The following is a description of a gene set: Murine Cytomegalovirus (MCMV) infection leads to early activation of various immune cells, including B and T lymphocytes, before the actual initiation of antigen-specific adaptive immunity. This activation is partly driven by innate cytokines, including type I interferon (IFN), which are induced early after infection. The objective of this study was to address the role of type I IFN in shaping early/innate B and T cell responses to a primary acute viral infection. In order to decipher the specific impact of IFN-I on cell subsets, we performed a genome-wide expression analysis on WT splenic B and CD8 T lymphocytes isolated from C57BL/6 mixed bone marrow chimera mice. This study complements series GSE39555, which focused on early responses of NK cells and of the two subsets of conventional dendritic cells. Human Gene Set: GSE45365_NK_CELL_VS_CD8_TCELL_MCMV_INFECTION_DN species: Homo sapiens Genes down-regulated during primary acute viral infection: NK vells versus CD8 T cells., and this is the list of marker genes: H2BC9, SEC61B, AKAP13, NFKB2, CHST7, TNFRSF1B, SND1, CHKB, PLAAT3, REPIN1, ETV3, H6PD, SMG9, SQSTM1, FAAH, B3GALT4, PSME2, ALOX15B, CD80, F11R (F11 receptor), EOLA1, TMEM268, TXN, SYNGR2, ACSM1, ZEB1, VPREB1, PRIM2, TNFAIP2, PIEZO2, ICOSLG, SPRED2, RAB5B, GBP1 (NCBI Gene Id 2633), CLU, NFKBIA, RAB11A, MPPED1, FSCN1, ACOXL, PSME1 (proteasome activator subunit 1), NAT8B, TRIP10, CLUHP3, PLK2, PRAME, HSPA8, LLGL2 (NCBI Gene Id 3993), CMTR1, STAP2, GPX4, NBL1, RAB8B, EOLA2, NFKB1, PPP1R16B, GATA6, SLC30A3, PSMD4, DUSP26, ST8SIA1, BIRC3, PTPN1, CEACAM1, GRK3, H3C10, GNG5, TBX5, GADD45A, EIF1, EDN1, TANK (NCBI Gene Id 10010), SLC2A6 (NCBI Gene Id 55587), THNSL2, SH3GL2, CDKN2A-AS1, ACY1, ACOX2, CDH11, UPB1, NRP2, CSNK1G3, MCC, UFD1, HAX1, MARCKSL1, CCDC81, ZMIZ2 (NCBI Gene Id 83637), LMBR1L, RFTN1, BMAL2, MIIP, ABCA7, LRRC8E, TRADD (TNFRSF1A associated via death domain), JAK3, CD40, TRAF1, SNN, LY75, LIPG, UNC13A, TNFRSF9, STX4, N4BP2L1, CERS6, SPON2, PRLH, RASSF4, MAP4K4, LSP1, KIF2A, EFR3B, CCL19, HTRA2, NCOA3, FLT3, IL2RA, BASP1, MED13L, NOSIP, ENOX1, PTGIS, MTCP1, MRPL46, RELB, SOCS2, TNIP1, TWF2, EBI3, DUSP1, EEF1A1, MED12, STAT5A, CLASRP, TAP1, CCL22, SLC5A6, MYBPC2, PSMC4, RNF115, CD70, REL, ZFTA, FOXO1, KRT19P2, POGLUT1, P2RY10, SLC1A2, CFP, PSMB10, ENSA, TNFRSF14, RPL13P5, TOMM34, MUC5AC, ENO3, HDLBP, MAP3K14, CDKL1, KMT2A, BATF3 (NCBI Gene Id 55509), NFIB, MVP, CYP2C19, FUT7, NR3C1, ANXA6, USP11, COA1, SRGN, SDC4, TRAFD1, IL15, SINHCAF, TNPO2, TBC1D8, TBC1D13, MGLL, RASSF2, IL21, HIVEP1, ELMO2, DCAF6, HLA-F (major histocompatibility complex, class I, F), ALDH2, TBC1D4, IRF1, CSTA (cystatin A), FAM117A, CSF2RA, SPECC1L, TNFAIP3, NAP1L4, GADD45B (growth arrest and DNA damage inducible beta), SLAMF7, CDKN1A, H2AZ1, IL15RA, PDE4B